Given this list of marker genes Gigyf2, Dcun1d4, Ptpn20, Rgs6, Nrip3, Slc24a2, Prkca, Dnajc11, Anapc7, Gpr17, Cdh8, Zfp850, Tia1, Arrdc3, Vnn1, Akap8, Ccdc198, Txlng, Ribc2, D430041D05Rik, Camk2g, Kpna3, Ube4a, Dele1, Slitrk2, Mettl21e, Dipk1a, Sycp3, Myrip, Rbm39, Epha4, Ddx11, Col12a1, Srsf3, Usp4, Ank, Emx2, Lrp8, Tusc2, Zfp334, Csnk1g3, Hhip, Tbc1d5, Nrip1, Shisa9, Pdpn, Cav3, Elavl4, Dhx15, Hdhd2, Plxna4 (NCBI Gene Id 330281), Adgrg2 (NCBI Gene Id 237175), Efna5, Gga3, Tspan1, Spry2, Atg14, Pigh, Vps29, Gucy2f, Slitrk4, Klrg2, Asic4, Galnt11 (polypeptide N-acetylgalactosaminyltransferase 11), Wdr91, Reep5, Med19, here is a description of the gene set: Mouse Gene Set: MIR_6963_3P Genes predicted to be targets of miRBase v22 microRNA mmu_miR_6963_3p in miRDB v6.0 with MirTarget v4 prediction scores > 80 (high confidence targets). studied in species Mus musculus from publication Chen Y, Wang X (PMID 31504780)